The following is a description of a gene set: Sudden unexpected death in epilepsy (SUDEP) is a sudden, unexpected, witnessed or unwitnessed, non-traumatic and non-drowning death, occurring in benign circumstances, in an individual with epilepsy, with or without evidence for a seizure and excluding documented status epilepticus, in which postmortem examination has not revealed a cause of death. species: Homo sapiens Human Gene Set: HP_SUDDEN_UNEXPECTED_DEATH_IN_EPILEPSY Sudden unexpected death in epilepsy, and this is the list of marker genes: CPLX1, UBR7, SLC32A1, SHQ1, SCN8A, GUF1, WWOX, FIG4, TBC1D24, SCN1A